The following is a description of a gene set: Human Gene Set: SEAVEY_EPITHELIOID_HEMANGIOENDOTHELIOMA from publication Seavey CN, Pobbati AV, Hallett A, Ma S, Reynolds JP, Kanai R, Lamar JM, Rubin BP (PMID 33766982) Genes overexpressed in Epithelioid Hemangioendothelioma versus Angiosarcoma, Kaposi Sarcoma, Hemangioblastoma, and Liver Epithelioid Hemangioendothelioma (EHE) is a studied in species Homo sapiens, and this is the list of marker genes: ABCA4, TMPRSS3, ANKRD33, EDN1, TNFRSF12A, SRPX2, MAFF, MMP19, SEMA3D (NCBI Gene Id 223117), ANKRD1, MYL2 (myosin light chain 2), MMRN1, NEXN, TRIM58, ITGA3, OR6B2, MELTF, SSC4D, ANKRD2, FBLN7, ANXA3, PPP1R13L, TNFRSF21, WT1, TINAGL1, MICB, PLAT, CUBN, MYOZ2, HTR2B, HRCT1, MSRB3, NXNL2, CCN1, EFEMP1, STON1, MYLK3, SERPINE1, CDH13, C17orf67, FOXF1, ERAP2, WTIP, CACNG6, SH2D1B, SLC24A1, NPAS1, BACE2, LATS2, TGFB2, COL8A1, SCARF2, NRGN, C1QTNF2, SELP (selectin P), GDF15, OSGIN2, NUDT4, BMP4, UPK1B, GDF3, HOXA1, SLC52A3, BMP6 (bone morphogenetic protein 6), CTNNAL1, FSTL3, KIF26B, KCNV1, CRLF2, FOXC2, FMOD (NCBI Gene Id 2331), FGF2, VEPH1, MXRA7, NCEH1, SLC6A4, PDE3A, LTBP1, C12orf75, C17orf58, TNFSF15, EHD2, CDC42EP5, PLCD3, PDLIM4, SMPDL3B, KCNN2 (potassium calcium-activated channel subfamily N member 2), LAMP3 (NCBI Gene Id 27074), ANGPT2, PRKAR2B, FHL2, CYB5B (NCBI Gene Id 80777), MAFA